The following is a description of a gene set: species: Homo sapiens from publication Chen Y, Wang X (PMID 31504780) Human Gene Set: MIR6788_3P Genes predicted to be targets of miRBase v22 microRNA hsa-miR-6788-3p in miRDB v6.0 with MirTarget v4 prediction scores > 80 (high confidence targets)., and this is the list of marker genes: TIGD5, L1TD1, COL4A2-AS2, ZNF655, BAGE2, ODAD2